The following is a description of a gene set: Human Gene Set: GOBP_ODONTOGENESIS species: Homo sapiens The process whose specific outcome is the progression of a tooth or teeth over time, from formation to the mature structure(s). A tooth is any hard bony, calcareous, or chitinous organ found in the mouth or pharynx of an animal and used in procuring or masticating food., and this is the list of marker genes: ENAM, ANKH, NGFR, CSF3R, SMO, CTNNB1, DMRT3, STIM1, LEF1, LAMA5, CNNM4, DLX2, ROGDI, MSX1, NFIC, SP7, TGFB3, CEMP1, AXIN2 (axin 2), KLK5, ITGB6, HAND1, FGF10, IFT80, CSF1, OSR2, CFTR, PPARA (NCBI Gene Id 84730), CTNNA1, AMELY, GLI3, RUNX2, TNFRSF11B, AMBN, SCN10A, ACVR2B, WNT6, GLI2, CD34, TNC, COL1A1, KLK4, DMP1, DSPP, EDA, ANKRD11 (ankyrin repeat domain containing 11), TNFSF11, BMP7, OSR1, SMPD3, BCOR, ID3, TGFB2, JAG2, AQP1, BCL11B, DLX1, TCIRG1, FGF4, SLC24A4, AQP3, HAND2, SHH, FST, SRC, PITX2, APCDD1, EDN1, BMP2, ASPN, HACD1, TBX1, BSG, TP63, SP6, NECTIN1, AQP6, HDAC1, FGF8, FAM20A, NF2, FGFR2, PERP, FOXI3, SERPINE1, SOSTDC1, TFAP2A, FAM20C, PHEX, RHOA, WNT10A, ODAM, BMPR1A, ZNF22, BMP4, TUFT1, BAX, SLC34A1, ACVR2A, TMT1A, MSX2, EDAR, MMP20, ODAPH, RSPO2, AMTN (amelotin), DLX3, TSPEAR, RELT, PDGFRA, SSUH2 (ssu-2 homolog), PAX9, NKX2-3, SCN5A, TRAF6, ALPL, FOXC1, TGFB1, HDAC2, AQP5, AMELX, ACP4, INHBA, COL1A2 (collagen type I alpha 2 chain), SLC4A2, FGFR1, WLS, BCL2L11, SNX10, LAMB1, LRP4